The following is a description of a gene set: A vascular malformation resulting from a developmental error of venous tissue composed of dysmorphic channels lined by flattened endothelium and exhibiting slow turnover. A venous malformation may present as a blue patch on the skin ranging to a soft blue mass. Venous malformations are easily compressible and usually swell in thewhen venous pressure increases (e.g., when held in a dependent position or when a child cries). They may be relatively localized or quite extensive within an anatomic region. Human Gene Set: HP_VENOUS_MALFORMATION Venous malformation species: Homo sapiens, and this is the list of marker genes: MSX2, CCM2, AKT1, KRIT1, PIK3CA, PDCD10, TEK, RASA1, GLMN (NCBI Gene Id 11146), ALX4